The following is a description of a gene set: species: Homo sapiens Pathway Definition from KEGG: APP* -> Abeta -> MAP3K5 -> MAP2K7 -> JNK Human Gene Set: KEGG_MEDICUS_VARIANT_MUTATION_CAUSED_ABERRANT_ABETA_TO_IRE1A_JNK_SIGNALING_PATHWAY Mutation-caused aberrant Abeta to IRE1a-JNK signaling pathway. Pathway ID: N01014. Pathway type: Variant. Pathway class: nt06534 Unfolded protein response., and this is the list of marker genes: MAP2K7 (NCBI Gene Id 5609), APP, MAPK10, MAPK8, MAP3K5, MAPK9